Given this list of marker genes TBX15, COL6A2, ESCO2, MMP2, FBN2, CADM3, ADGRG6, PRG4, SPG11, COL6A1, ERGIC1, ANO5, DDR2, DLK1, MAP3K7 (NCBI Gene Id 6885), CAPN3, MEG3 (NCBI Gene Id 55384), ERCC1, B3GALT6, SCYL2, MYL11, FLNA, PI4KA, LMNA, TNNT1, MECP2, ASXL1, MUSK, ADAMTSL2, TUBB3, RTL1, COL6A3 (collagen type VI alpha 3 chain), FILIP1 (filamin A interacting protein 1), HSPG2, MYH3, ERLIN2, COL25A1, PAX3, DHX16, COL12A1, here is a description of the gene set: studied in species Homo sapiens A chronic loss of wrist joint motion due to structural changes in muscle, tendons, ligaments, or skin that prevent normal movement of the joints of the wrist. Human Gene Set: HP_WRIST_FLEXION_CONTRACTURE Wrist flexion contracture